Given this list of marker genes Gar1, Rpusd2, Nhp2, Rpusd1, Nop10 (NOP10 ribonucleoprotein), Tsr3, Rpusd4, Naf1, Dkc1, here is a description of the gene set: Mouse Gene Set: GOBP_RRNA_PSEUDOURIDINE_SYNTHESIS The intramolecular conversion of uridine to pseudouridine in an rRNA molecule. species: Mus musculus